The following is a description of a gene set: Mouse Gene Set: GOBP_INTERLEUKIN_5_PRODUCTION The appearance of interleukin-5 due to biosynthesis or secretion following a cellular stimulus, resulting in an increase in its intracellular or extracellular levels. species: Mus musculus, and this is the list of marker genes: Tslp, Gata3, Il1rap, Prkcz, Il9, Il33, Foxp3, Il5ra, Il25, Tnfrsf21, Il1rl1, Epx, Rara, Pde4d (NCBI Gene Id 320753), Il17ra, Nlrp3, Il17rb, Lilrb4a, Lef1, Lilrb4b, Crlf2, Scgb1a1